Given this list of marker genes Slc11a1, Pcdhb5, Spmip6, Loxl3, Spata17, Fbxo34, Tjp1, Cypt1, Usp15, Ube3d, Ndufc2, Nol4l, Ireb2, Iscu, Obp2a, Bcl2l11, Plcxd1, Cypt12, Cypt4, Ppp1r2, B3galnt1, Ugt2a3, Mpeg1, Pcdh20, Tmem170b, P4ha1, Trim42, Htr2a, Med27, Zfp735, Spag9, Dnajc10, Pheta1, 4930480E11Rik, 4930503L19Rik, Dpys, Cypt3, Opa1, here is a description of the gene set: from publication Chen Y, Wang X (PMID 31504780) Mouse Gene Set: MIR_7677_5P species: Mus musculus Genes predicted to be targets of miRBase v22 microRNA mmu_miR_7677_5p in miRDB v6.0 with MirTarget v4 prediction scores > 80 (high confidence targets).